The following is a description of a gene set: Catalysis of the reaction: retinal + NAD+ + H2O = retinoate + NADH. Acts on both 11-trans and 13-cis forms of retinal. species: Mus musculus Mouse Gene Set: GOMF_RETINAL_DEHYDROGENASE_ACTIVITY, and this is the list of marker genes: Dhrs4, Akr1c12, Akr1c14, Akr1b10, Akr1b1, Akr1c19, Akr1c6, Akr1c18 (aldo-keto reductase family 1, member C18), Aldh1a2, Akr1c21, Akr1c13, Akr1cl, Aldh1a3, Akr1c20, Aldh8a1, Akr1b7, Akr1b8, Aldh1a1